Given this list of marker genes Sco2, Atp7a, Prnd, App, Arf1, Commd1, Ccdc22, Atp7b, Slc31a1, Aplp2, Cp, Sco1, Cox10 (NCBI Gene Id 70383), Atox1, Prnp, Ankrd9, Abcb6, Slc31a2, Cox19, here is a description of the gene set: Any process involved in the maintenance of an internal steady state of copper ions within an organism or cell. Mouse Gene Set: GOBP_COPPER_ION_HOMEOSTASIS studied in species Mus musculus